Given this list of marker genes UVRAG, FYCO1, SMCR8, TOM1, IRGM, ADRB2 (NCBI Gene Id 154), CALCOCO2 (NCBI Gene Id 10241), here is a description of the gene set: Any process that activates or increases the frequency, rate or extent of autophagosome maturation. Human Gene Set: GOBP_POSITIVE_REGULATION_OF_AUTOPHAGOSOME_MATURATION species: Homo sapiens